The following is a description of a gene set: Mouse Gene Set: GOMF_WIDE_PORE_CHANNEL_ACTIVITY studied in species Mus musculus Enables the energy-independent facilitated diffusion of propanediol through a large pore, un-gated channel. Examples include gap junctions, which transport substances from one cell to another; and porins which transport substances in and out of bacteria, mitochondria and chloroplasts., and this is the list of marker genes: Gjb2, Bak1, Tomm40l (NCBI Gene Id 641376), Gsdme, Vdac2, Gsdmc (gasdermin C), Gja4, Gsdmc3, Pfpl, Gja10, Gjc2, Gje1, Mpeg1, Vdac3, Gjd2, Gja6, Gjb3, Gja3, Gsdmc2, Gjc3, Panx3, Gjd4, Gja8, Gjc1, Gjb5 (NCBI Gene Id 14622), Tomm40, Gsdma3, Gsdma (NCBI Gene Id 57911), Vdac1, Gsdmc4, Gjb4, Gja1, Gsdmd, Panx1, Gjb1, Gja5, Gsdma2, Gjb6, Gjd3, Prf1, Panx2